The following is a description of a gene set: Human Gene Set: HP_NARROW_FACE Narrow face Bizygomatic (upper face) and bigonial (lower face) width are both more than 2 standard deviations below the mean (objective); or, an apparent reduction in the width of the upper and lower face (subjective). species: Homo sapiens, and this is the list of marker genes: MICU1, SIN3A, ERCC4 (NCBI Gene Id 7509), KLHL41, CENPE, CEP152, TRAIP, ZFX, AP4E1, TBL2, TUBB4A, MTM1, KMT2D, NEB, RECQL4, LIG4, CLIP2, CHD7, ACTA1, FKBP6, ANTXR2, NUP85, CTCF, TPM3, EFEMP1, TRIP11, NSDHL, MEGF8, PPP1R15B, TBX1, UBE3B, MYH3, TNNT3, NALCN, MAP2K2, NHS, PBX1 (PBX homeobox 1), TPM2, DNA2, MED12 (mediator complex subunit 12), EIF4H, NGLY1, VPS37D, NSD1, RAB23, ATP7A, RYR3, NOTCH3, RYR1, UPF3B, FBN1, TMEM270 (transmembrane protein 270), SIX1, APC2, STRADA, DNAJC30, GTF2I, ATR, SLC6A8, LMNA, METTL27, PCNT (pericentrin), FMR1, WRN, BAZ1B, STX1A, DSTYK, SEMA3E, HYOU1, CHRNB1, KBTBD13, RBBP8, RLIM, NSUN2, CENPT, EYA1, TSPAN7, LMOD3, ZDHHC9, COL18A1, HECTD4, GTF2IRD2, ATRIP, SLC37A4, LIMK1, BCOR, GTF2IRD1, PQBP1, TNNI2, SMS, NFIX, ELN, TRMT10A, SLC9A6, CFL2, FBXL4, PAX3, NCF1, BUD23, BLM, SLC16A2, RFC2, MYPN, STEEP1, PLK4, NOG, RFX7, SATB2